The following is a description of a gene set: Reactome Pathway: Lysosome Vesicle Biogenesis Proteins that have been synthesized, processed and sorted eventually reach the final steps of the secretory pathway. This pathway is responsible not only for proteins that are secreted from the cell but also enzymes and other resident proteins in the lumen of the ER, Golgi, and lysosomes as well as integral proteins transported in the vesicle membranes. Here the proteins in this secretory pathway are ultimately found in lysososmes. studied in species Homo sapiens part of: trans-Golgi Network Vesicle Budding, and this is the list of marker genes: CLTC, HSPA8, M6PR, AP1M1, CHMP2A, CTSZ, AP4M1, HGS, BLOC1S1 (biogenesis of lysosomal organelles complex 1 subunit 1, NCBI Gene Id 81990), AP4E1, CLTB, SH3GL2, CLVS1, AP1G1, AP1G2, DNM2, AP1M2, CLVS2, AP4B1, GNS, AP1B1, AP1S3, VAMP7, DNASE2, TXNDC5, ARF1, CLTA, AP4S1, AP1S1, DNAJC6, AP1S2, VAMP2, ARRB1, APP, VAMP8